The following is a description of a gene set: Human Gene Set: HP_PANCREATIC_ENDOCRINE_TUMOR species: Homo sapiens A neuroendocrine tumor originating in a hormone-producing cell (islet cell) of the pancreas. Pancreatic endocrine tumor, and this is the list of marker genes: TSC1, KCNJ11, MEN1, CDKN1A, CCND1, CDKN1B, CDKN2C, VHL, TSC2, IFNG, GCGR, MAFA, CDKN2B